The following is a description of a gene set: Genes negatively differentially expressed in cell type: MigDC (migratory dendritic cell) upon treatment with cytokine: EGF in mouse lymph nodes in vivo. from publication Cui A, Huang T, Li S, Ma A, Pérez JL, Sander C, Keskin DB, Wu CJ, Fraenkel E, Hacohen N (PMID 38057668) Mouse Gene Set: CUI_MIGDC_EGF_RESPONSE_DN Cytokines mediate cell-cell communication in the immune system and represent important therapeutic targets. A myriad of studies have highlighted their central role in immune function, yet we lack a global view of the cellular responses of each immune cell type to each cytokine. To address this gap, the authors created the Immune Dictionary, a compendium of single-cell transcriptomic profiles of more than 17 immune cell types in response to each of 86 cytokines (>1,400 cytokine-cell type combinations) in mouse lymph nodes in vivo. A cytokine-centric view of the dictionary revealed that most cytokines induce highly cell-type-specific responses. For example, the inflammatory cytokine interleukin-1β induces distinct gene programmes in almost every cell type. A cell-type-centric view of the dictionary identified more than 66 cytokine-driven cellular polarization states across immune cell types, including previously uncharacterized states such as an interleukin-18-induced polyfunctional natural killer cell state. studied in species Mus musculus, and this is the list of marker genes: Marcks, Rgs1, Zfp36, Dusp1, Klf6